Given this list of marker genes DYNC2I1 (dynein 2 intermediate chain 1), HOXA13, PPP1R12A, DYNC2H1, AXIN1, FZD2, IFT80, GATA3, INTU, DYNC2I2 (dynein 2 intermediate chain 2), WDR35, WT1, here is a description of the gene set: studied in species Homo sapiens A malformation of the uterus in which the uterus is present as a paired organ as a result of the failure of fusion of the mullerian ducts during embryogenesis. Human Gene Set: HP_UTERUS_DIDELPHYS Uterus didelphys